Given this list of marker genes FIG4, PI4K2A, PIK3R3, BPNT2, INPP5E, IP6K2, INPP1, IMPA1, PIK3C2G, PIPSL, ATG14, OCRL, PIK3C2B, HYCC1, PI4K2B, INPP4A, PIKFYVE (phosphoinositide kinase, FYVE-type zinc finger containing), PIP5KL1, PIP4K2C, IP6K3, PIK3C3, PIP5K1A, PIP5K1B, TTC7A, PIK3CG, PIK3R1, SMG1, ITPKC, PIK3CA, INPP4B, PIK3R4, ATM, TMEM150A, PI4KB, PIK3CD, HYCC2, PI4KAP2, BECN1, SYNJ1, ITPKB, EFR3A, PI4KA, BPNT1, SYNJ2, UVRAG, PIP4K2B, PTPRQ, ITPKA, PIP4K2A, IMPA2, PIK3C2A, EFR3B, PIK3CB, TTC7B, IP6K1, PIP5K1C, here is a description of the gene set: The chemical reactions and pathways resulting in the formation of phosphatidylinositol phosphate. species: Homo sapiens Human Gene Set: GOBP_PHOSPHATIDYLINOSITOL_PHOSPHATE_BIOSYNTHETIC_PROCESS